Given this list of marker genes GAL, FMR1, LRRC38, CBARP, LRRC26, HPCA, CACNG8, FGF13, CAMK2D (NCBI Gene Id 817), PRKCD, GPR35, CNIH3, CACNG7, HAP1, CALM1, OSR1, OPRM1, HTT, KCNE1 (NCBI Gene Id 3753), CACNB3, AHNAK, FGF12, CRACR2A, SHISA7, CACNG5, ACTN4, WNK2, CFTR, CTTNBP2NL, SYNGR3, TMSB4X, SGK1 (NCBI Gene Id 6446), KCNRG, ATP2A1, ANK3, KCNE2, ACTN2, NIPSNAP2, TESC, CRHBP, SPHK2, JPH2, MMP9, CACNG4, SELENON, KCNE3, STK39, CACNG3, CALM2, SGK2, VAMP2, SCN1B, LRRC52, PHB2, AHCYL1 (adenosylhomocysteinase like 1), KCNQ1, WNK3 (NCBI Gene Id 65267), ATPSCKMT, EDN1, CACNA1F, MINK1, GNB5, TCAF1, STIM2, NDFIP1, WWP2, TRPC6, COX17, KCNAB1, TLR9, EDNRA, GALR2, GOPC, CRH, CRHR1, CNIH2, ASPH, CTSS, SUMO1, STIM1, PIM1, UBQLN1, CASQ1, LRRC55, CALM3, STAC2, VMP1, NDFIP2, STRIT1, TCAF2, CACNG2, DAPK1 (NCBI Gene Id 1612), STAC, CHP1, PLN, STAC3, GRP, PRRT1, SLN, STIMATE, PPIF, CACNB4, here is a description of the gene set: studied in species Homo sapiens Human Gene Set: GOBP_REGULATION_OF_TRANSPORTER_ACTIVITY Any process that modulates the activity of a transporter.